The following is a description of a gene set: Major pathway of rRNA processing in the nucleolus and cytosol Mouse Gene Set: REACTOME_MAJOR_PATHWAY_OF_RRNA_PROCESSING_IN_THE_NUCLEOLUS_AND_CYTOSOL species: Mus musculus, and this is the list of marker genes: Rpl24, Emg1, Rps27rt, Nop58, Rpl31, Ftsj3, Rps21, Rpl39, Tsr1, Heatr1, Rps15a (NCBI Gene Id 319296), Utp3, Exosc7, Rpl35, Wdr36, Rplp1 (NCBI Gene Id 80450), Isg20l2, Exosc4 (exosome component 4), Imp4, Rps17, Fbl, Rps8, Nol9, Fcf1, Ddx47, Utp11, Fau, Rps14, Imp3, Rpl12, Nob1 (NIN1/RPN12 binding protein 1 homolog), Rps27a, Ddx52, Rpl36, Pno1, Utp20, Rpl23, Rps18, Rpl10l, Wdr46, Rpl3, Rpl10-ps3, Dis3, Rps15, Rplp0, Bop1, Riok2, Mphosph10, Rpl26, Utp15, Rpl34, Exosc6, Uba52rt, Mphosph6, Rps6, Nop56, Rps27, Rpl21, Utp4, Pes1, Rps16, Rps26, Rpl36a-ps1, Ncl (NCBI Gene Id 319677), Exosc10, Rpl4, Riok3, Rps29, Rpl13a, Eri1, Rcl1 (NCBI Gene Id 98135), Rpl19, Rps23, Dhx37, Rpl17, Utp18, Utp14b, Rpl27a, Exosc5, Rpp14, Uba52, Wdr18, Rpl28, Rpl38, Rps25, Rpp38, Rplp2, Rpl22, Rpl8, Rps2, Krr1, Rps5, Nol6, Csnk1e, Rps28, Rpl32, C1d, Rpl9, Rps12, Rpl36a, Pdcd11, Utp25, Rps27l, Rps24, Rps20, Rpl39l, Wdr3, Bysl, Exosc2, Mtrex, Pwp2, Rpl14, Rps3a1, Exosc8, Rps19, Rpp25, Ebna1bp2, Utp6, Utp14a, Rpp40, Rps9, Rpl36al, Snu13, Rpl15, Exosc9, Rpl30, Rpl7, Pelp1, Rpl22l1, Bud23, Rps13, Xrn2, Rrp7a, Ddx21, Exosc3, Senp3, Csnk1d, Dcaf13 (DDB1 and CUL4 associated factor 13), Gm6525, Rpl3l, Noc4l, Gnl3, Nip7, Rps11, Nop14, Rpl18a, Rps7, Rpsa, Rpp30, Rpl37a, Rpl29, Nol11 (NCBI Gene Id 68979), Rpl5, Rrp36, Rpl7a, Rpp21 (NCBI Gene Id 67676), Rpl27, Wdr75, Tex10 (NCBI Gene Id 72812), Rpl23a, Tbl3, Rpl37, Rpl11 (ribosomal protein L11), Rpl6, Rpl35a, Exosc1, Rpl10, Las1l, Rps10, Bms1, Rpl13, Rps4x, Rpl35rt, Riok1, Wdr12, Wdr43, Ddx49, Rpl18, Rps3, Ltv1, Rrp9